The following is a description of a gene set: Genes down-regulated in multipotent progenitors versus pro-B cells. Human Gene Set: GSE37301_MULTIPOTENT_PROGENITOR_VS_PRO_BCELL_DN species: Homo sapiens from publication Ramirez K, Chandler KJ, Spaulding C, Zandi S, Sigvardsson M, Graves BJ, Kee BL (PMID 22608498) Expression profiling of Rag2-deficient Ets1++ and Rag2-deficient Ets1-- mature NK cells and WT bone marrow progenitors, WT T cells, and WT Pro B cells, and this is the list of marker genes: FANCC, ARRDC4, VRK1, SPTLC1, MAPK12, PPP4R4, AREG, ABLIM3, PTAFR, PLS3, CSF1 (NCBI Gene Id 1435), CLPTM1, ARHGEF7, FAH, FBXO30, ZFP36L1, ZHX1, FBXL20, CREB3L2, LACTB2, GGTA1, HMGCS1, PLIN2, KIF13A, PCK2, CPM, DDHD2, NDRG1 (NCBI Gene Id 7998), PGRMC1, RPS6KA1, SNX29, GAS2, SLC43A3, SNX12, KDSR, BCAP29, ANXA9, NPNT, RAB5A, ZFP1, ABCC3 (NCBI Gene Id 8714), IL10RA, CRISP1, DGAT1, CYSLTR1, BMP2K (BMP2 inducible kinase), CTNND1, PDE1B, PTGS1, FZD7, LRRC57, DNAJC12, CHST11, ZMYM3, RPN1, EGR3, RBM11, NPAS2, PCTP, TMED3 (NCBI Gene Id 23423), NFKBIZ, MXI1, KATNAL1, DDIT4, CERK, TRIP10, ANXA7, CD69, GALNT1, ERCC6, SYNJ2, ADARB1, IGFBP7, LATS2, AKAP7, BPGM, SYPL1, DUSP4, DECR2, ARMCX3 (armadillo repeat containing X-linked 3), NCK2, CD99L2, SLC9A6, CREM, LMNA, GATA3, RPS6KA5, PHTF2, SYTL1, RDH11, IQCE, TEX2, TMEM64, IMPA2, TPP1, MFGE8, PIK3CA, NMUR1, GLA, CACNB1, ARHGAP27, NAV2, FMN1, NADK, PDE8A, CAMK2N1, EHD4, AHCYL2, TDRD3, GGH, CEP170, GTF2IRD1, IL2RA, MGAT5, ABCA5, MLF1, GLUD1, IRAK2, TMEM170B, TMX2, RAB1A, MOB1B, TCN2, LIG4, KIT, PI4K2A, MTHFD2L, COPS2, PODXL, MUC1, TFRC, TSC22D1, ETV5 (NCBI Gene Id 2119), DUSP22, TUBB6 (tubulin beta 6 class V), ADAM15 (ADAM metallopeptidase domain 15), TMTC2, PIP4P2, SLC37A2, NRIP1, LRRC49, CCDC32, GM2A, SNUPN, CAST, TRPM4, CNNM2, ATP8A1, ITGAV, ST3GAL2, SERINC5, SLC38A10, PSEN2, UBE2F, TEC, VAMP7, CD80, STAP1, DNASE1L1, SRXN1, CAPNS2, CD200R1L, ANKRD6, RASSF6, HSF2, FAM185A, RNF152, PLCL1, RAB11A, FUCA2, FNIP2, PIGX, INSR, DCTD, AFF4, TMEM43, ERC1, AGPS, SORBS1